The following is a description of a gene set: Mouse Gene Set: MIR_6916_3P from publication Chen Y, Wang X (PMID 31504780) Genes predicted to be targets of miRBase v22 microRNA mmu_miR_6916_3p in miRDB v6.0 with MirTarget v4 prediction scores > 80 (high confidence targets). species: Mus musculus, and this is the list of marker genes: Btbd10, Tstd2, Ptprt, Slc25a36 (NCBI Gene Id 77659), Stambpl1, Otud7b, Iqgap2, Tmod3, Ush1g, Slc25a39, Arrb1, Zbtb10, Kcna1 (NCBI Gene Id 17205), Dync1li2, Hlf, Pax7, Tent4b, Tmco3, Arx, Dlk1, Chac2, Grik3, Pcsk6, Gpm6a, Tfg, Stard13, Sec61b, Chd2, Dmxl1 (Dmx-like 1), Scd3, Eya1, Arpc5, Znrf3, Aif1l, Cul4a, Kctd10, Dscaml1, Xpo1, Plpp6, Foxg1, Erc2, Maml1, Adamts19, Ppp2cb, Fam117a, St8sia6 (ST8 alpha-N-acetyl-neuraminide alpha-2,8-sialyltransferase 6), Sirt1, Zfp710, Adamts5, Ppp2r2d, Hic2, Simc1, Tnrc6b, Cfap418, Prrx1, B4galt4, Slc23a1, Cnnm2, Aak1, Tafa5, Tnn (NCBI Gene Id 329278), Rffl, Zbtb14, Nudt14 (NCBI Gene Id 66174), Dhx32, Fam199x, Itgae, Nr4a3 (NCBI Gene Id 18124), Fads1, Rint1, Nrp1, Gria2, Fbn1, Timm8a1, Tead1, Nell2, Cab39l, Pdik1l (PDLIM1 interacting kinase 1 like), Traf3, Cap1, 1810055G02Rik, Clta, Cul4b, Rab30, Epop, Mmgt1, Casp14, Col25a1, Slc6a1, Tpd52l1, Tmem33, Apold1, Itpripl2, Grm7, Cenatac, Dcun1d4, Gabpb1, Rarg, Ptbp1, Ldb2, Fndc10, Rwdd2a, Cers2, Dmxl2, Pou2f1, Ostf1, Lin28b, Kcnip4, Lin7c, Rab34, Crispld2, Ncald, Nr5a2, Ldlrap1, Elavl1, Rft1, Slfn14, Spry4, Pou2f2, Nkx2-1, Cntn1, Greb1l, Mlf1, Trappc6b, Alk, Camk1d (NCBI Gene Id 320468), Uba2, Acat3, Actr1a, Ckap4, Cnksr2, Fgf14 (NCBI Gene Id 14169), Ints8, Ankrd44, Psd3